The following is a description of a gene set: Abnormal CSF protein concentration Human Gene Set: HP_ABNORMAL_CSF_PROTEIN_CONCENTRATION Any deviation from the normal range of a protein concentration in the cerebrospinal fluid. studied in species Homo sapiens, and this is the list of marker genes: MT-CO1, MT-ND1, CACNA1A, EIF2B5, SUMF1, BCAT2, MT-CO2, UNC93B1 (unc-93 homolog B1, TLR signaling regulator), HLA-DRB1, MT-TL1, MT-TW, TYMP, TLR3, MT-ND5, MPV17, HLA-DQB1, PRX, LMNB1, EGR2, MT-TF, PRNP, MT-TH, SCN1A, POLG, PRF1, MT-ND6, GALC, CD59, TBK1, PRRT2 (proline rich transmembrane protein 2), PHYH, MT-TS2, OCLN (occludin), SLC12A6, PEX7, NDUFS4, NGLY1, GBE1, GFAP, MT-ATP8, RANBP2, MT-CO3, ABHD5, ARSA, BTNL2 (NCBI Gene Id 56244), ATP1A2, TICAM1, NOTCH2NLC, MT-ND4, PSAP (prosaposin), ALDH4A1, MICU1, TRAF3, PSMB9, TXN2, MT-TQ, RRM2B, SLC12A2, PMP22, FTL, MPZ, TTR, LIG3